Given this list of marker genes HMGCS2, KIF20A, LLGL2 (LLGL scribble cell polarity complex component 2), RAPGEFL1, MDK, ATP2B4, ASS1, IMPA2, LTF, CPE, ADD3, EMP2, RET, MEST, NAB2, IGFBP4, KCNK5, TJP3, DHCR7, CHST8, RPS6KA2, ID2, PLAC1, SLC16A1, CKB, SNX10, OPN3, FDFT1, HSPA4L, SLC29A1, METTL3, CCN5, BTG3, PRKAR2B, ANXA9, S100A9, SIAH2, TST, IDH2, SERPINA5, CISH, AREG, IL6ST, RBBP8, FABP5, CCNA1, TPD52L1, SLC1A4, MOCS2, ALDH3B1, LARGE1, XRCC3, PDCD4, SERPINA3, CD9, PTGES, CACNA2D2, NRIP1, CD44, XBP1, GPER1, CDC20, COX6C, ACOX2, OVOL2, ST6GALNAC2, SCNN1A, TMPRSS3, CXCL14, ITPK1, TOB1, CHPT1, TFAP2C, SLC24A3, GLA, WFS1, DNAJC1, ASCL1, ARL3, DLG5, TNNC1, KRT19, UGDH, ALDH3A2, EEIG1, PKP3, ZFP36, JAK1, CDH1 (NCBI Gene Id 999), SEMA3B, FARP1, SCUBE2, KLF4 (KLF transcription factor 4), HSPB8, BATF, TPSAB1, PDLIM3, SOX3, PPIF, BAG1, NHERF1, PDZK1, DHRS2, CAV1, RNASEH2A, GJB3, ABHD2, UNC13B, TFF1, SULT2B1, MAPT, TSPAN13, TRIM29, PLXNB1, SLC27A2, MYOF, KRT13, GAL, NMU, CALCR, FKBP4, ISG20, BLVRB, TFF3, BCL2 (NCBI Gene Id 596), NCOR2, SGK1, AMFR, FKBP5, NXT1, DCXR, PLAAT3, ETFB, CA12, HOMER2, DUSP2, AFF1, TFPI2, FGFR3, TPBG, SFN, STIL, TIAM1, DNAJC12, OLFM1, LSR, ABCA3, JAK2, FLNB, AGR2, KLK10, SORD, PRSS23, PRLR, CXCL12 (NCBI Gene Id 6387), SLC26A2, HR (HR lysine demethylase and nuclear receptor corepressor), SERPINA1, RAB31, CCND1, CYP4F11, DYNLT3, MYB, PERP, ELOVL5, SCARB1, PAPSS2, PGR, SLC22A5, NBL1, ST14, MAPK13, CLIC3, MICB, IGSF1, IL17RB, EGR3, HPRT1, NPY1R, FOS, GFUS, GINS2, TOP2A, CA2, GALE, CYP26B1, PLK4, PCP4, FOXC1, PTPN6, SLC7A5, CDC6, KLK11 (NCBI Gene Id 11012), RABEP1, CELSR2, LAMC2 (laminin subunit gamma 2), SLC2A8, TH, FRK (fyn related Src family tyrosine kinase), PTGER3, here is a description of the gene set: from publication Liberzon A, Birger C, Thorvaldsdóttir H, Ghandi M, Mesirov JP, Tamayo P (PMID 26771021) Human Gene Set: HALLMARK_ESTROGEN_RESPONSE_LATE studied in species Homo sapiens Genes defining late response to estrogen.